Given this list of marker genes BTRC, TNFRSF1B, TGIF2, MEN1 (NCBI Gene Id 4221), RPL21, PSMD5, LDHC, MAPKBP1, CYC1, LIG1 (NCBI Gene Id 3978), TUBB2A, HDGF, RGS2, GATA6, RAD51, RARG, ISG15, CDK2AP2, PCCB, MATN4, SH3GL2, PAFAH1B3, SPG7, POU2F2, PTTG1, SPTA1, FBXO46, ADGRE5, NINJ1, YIPF1, ITGB7, RAB13 (RAB13, member RAS oncogene family), MICAL3, HBD, GALNT2, RASSF9, ALDH1B1, VAC14, IPO9 (NCBI Gene Id 55705), CACNB2, PPIL2, ELOVL2, SELE, ZNF140, IVD, ICOS, SLC5A2, MEST, SCCPDH, ARAP1, ARHGAP44, SIVA1, RTN2, LOXL1, CNOT9, NDUFA6, LDAF1, ABI2, TAP1, PDGFRL, BICRAL, CD72, APOB, RNF139, LASP1, GPR4, SLC19A1, HS2ST1, RBM4B (RNA binding motif protein 4B), CXCL3, GADD45A, TXNL4A, ID3, OS9, ECI1, PHKG1, BCAT2, CYP4F2, DUSP5, ROS1, SIX1, IL12B, IFNAR1, FAM53B, CD52, COG2, KCNJ8, TRAF1, CX3CR1, ADORA2A, WNT8B, CBX5, DNTT, GNRH1, HOXB2, JADE3, COX6C, NME5, PTEN, PRKAA2, ALDH1A1, WASF1, INPP5A, UHRF2, TMEM97, IL16, NDP, UQCRFS1, MARCO, NTS, ANXA2P1, LCN1, DDIT4, SEPHS2, EPHB6, RBM17, POP7, GSS (NCBI Gene Id 2937), FCER1G, EHMT2, APOBEC3B, FAP, LRP10, TCAF1, H3-3B, ACADVL, SMPD2, DNAJC9, MARCHF2 (NCBI Gene Id 51257, membrane associated ring-CH-type finger 2), SH3BP5, PTENP1, BRME1, IFNGR2, APOBEC3G, PNLIPRP2, GNG4, UNC13A, RBM5, AMPD2, ESRRA, FGFR1, DBI, STAT2, S1PR4, SLC16A3, ECPAS, RUNX3, IRF7, BLZF1, R3HDM1, ATOX1, CYB5R3, PF4V1, TNPO2, PITPNM1, SULT1A1, MAD1L1, TNFAIP1, GYPC, C1orf21 (chromosome 1 open reading frame 21), GUSB, DCTN3, LDB1, KSR1, ACTR1B, PLOD3, ADM, SP4, VILL, PPIF, GRM7, SRSF6, RGS10, TFAP4, SCRIB, TCFL5, CD81, TIMELESS, SMS, PDXDC1, HOPX, RGS14, GTF2H2, RPP30, PPP6R2 (NCBI Gene Id 9701), AGT, CD5L, CCND1, CXCL2, CASP2, GDF10, PELP1, ZNF165, NDUFS8 (NADH:ubiquinone oxidoreductase core subunit S8), GTPBP6, RRP8, PC, MAGEB2, here is a description of the gene set: from publication Kitano M, Moriyama S, Ando Y, Hikida M, Mori Y, Kurosaki T, Okada T (PMID 21636294) We found that a number of Tfh cells downmodulated BCL6 protein after their development, and we sought to compare the gene expression between BCL6-hi Tfh cells and BCL6-low Tfh cells. Genes up-regulated in BCL6 low follicular helper T cells versus naïve CD4 T cells. Human Gene Set: GSE24574_BCL6_LOW_TFH_VS_NAIVE_CD4_TCELL_UP studied in species Homo sapiens